Given this list of marker genes Klrc2, Syk, Klrd1, Klrc3, Siglecg, Cd300e, Lcp2, Klrk1, Trem1, Grap2, Cd300lb, Pik3cb, Lck, Shc1, Lat, Pik3r2, Tyrobp, Grb2, Klrc1, Trem2, B2m, Hras, Plcg2, Fyn (Fyn proto-oncogene), here is a description of the gene set: electronically inferred by orthology from the curated human pathway This event has been computationally inferred from an event that has been demonstrated in another species.<p>The inference is based on the homology mapping from PANTHER. Briefly, reactions for which all involved PhysicalEntities (in input, output and catalyst) have a mapped orthologue/paralogue (for complexes at least 75% of components must have a mapping) are inferred to the other species. part of: Innate Immune System Reactome Pathway: DAP12 interactions species: Mus musculus